The following is a description of a gene set: Genes predicted to be targets of miRBase v22 microRNA mmu_miR_762 in miRDB v6.0 with MirTarget v4 prediction scores > 80 (high confidence targets). Mouse Gene Set: MIR_762 species: Mus musculus from publication Chen Y, Wang X (PMID 31504780), and this is the list of marker genes: Tagln, Kcng1 (potassium voltage-gated channel, subfamily G, member 1), Thap11, Nfix, Ucp2, 5031439G07Rik, Adarb2, Gnai2, Slc36a1, Pik3c3, Phc3, Carns1, Gm6878, Mxi1, Mdga1, Tnrc6b, Igsf8, Abcf2 (ATP-binding cassette, sub-family F member 2), Zfp821, Mb, Aldoa, Gnao1, Thbs4, Emilin3, Slc38a3, Zfp609, Abcg4, Bod1l, Dagla, Prkca, Timm17b, B4galt2, Son, Samd4b, Mras, Misp3, Recql, Slc16a6, Zfp568, Hip1, Zfp617, Acot11, Trabd, Stk39, Anks1b, Wdfy3, Irf2, Nectin1, Rap1gap2, Zfp219, Tanc2, Sh3pxd2a, Cep170b, Zfp92, Abl1, Hnrnpk, Crat, Ap1m1, Atg4b, Sftpa1, Cdc42se1, Kcnip3, Kcnk3, Kl, Stk40, Ncstn, Mfng, Bcl11a, Map6d1, Mpl, Pnck, Clcnka, Atf7ip, Aldoart1, Sprtn, Zbtb4, Pacs1, Gprc5c, Gsk3a, Cuedc1, Ptprf, Hectd3, Jmjd8, Slc1a7, Sdc3, Mettl26, Adgra2, Slc8a1, Grin1os, Cbx6, Larp1, Phf24, Gpr107, Dlg2, Bptf, Zer1 (NCBI Gene Id 227693), Znrf1, Rnf150, Zfp446, Ctdp1, Tgs1, Mlc1, Neu2, Cotl1, Zhx3, Tigd5, Cbfa2t3, Grm2, Cyp26b1, Fkbp5, Tmem222, Creb5, Iqsec2, Natd1, Plekhb2, Rapgef1, Pdpn, Col1a1, Slc38a1, Rexo1, Kcnk5, Ptpn23, Wipf2, Pfkfb4, Adgrl1, Fam163a, Usp50